The following is a description of a gene set: Cluster 2: genes down-regulated in lung tissue samples from mice with oncogenic form of KRAS and inactivated PTEN. from publication Iwanaga K, Yang Y, Raso MG, Ma L, Hanna AE, Thilaganathan N, Moghaddam S, Evans CM, Li H, Cai WW, Sato M, Minna JD, Wu H, Creighton CJ, Demayo FJ, Wistuba II, Kurie JM (PMID 18281487) Phosphatase and tensin homologue deleted from chromosome 10 (Pten) is expressed aberrantly in non-small cell lung cancer cells, but the role of Pten in lung neoplasia has not been fully elucidated. In this study, we used a genetic approach to inactivate Pten in the bronchial epithelium of mice. Although, by itself, Pten inactivation had no discernible effect on bronchial epithelial histology, it accelerated lung tumorigenesis initiated by oncogenic K-ras, causing more rapid lethality than that induced by oncogenic K-ras alone (8 weeks versus 24 weeks of median duration of survival, respectively). Lung tumors arose in K-ras mutant, Pten-deficient mice that rapidly obstructed bronchial lumina and replaced alveolar spaces. Relative to K-ras mutant tumors, the K-ras mutant, Pten-deficient tumors exhibited more advanced histologic severity and more prominent inflammation and vascularity. Thus, Pten inactivation cooperated with oncogenic K-ras in promoting lung tumorigenesis. Mouse Gene Set: IWANAGA_CARCINOGENESIS_BY_KRAS_PTEN_DN studied in species Mus musculus, and this is the list of marker genes: 4933425D22Rik, Cir1, Ttll8, Hk1, Scfd2, Smg9, 4930532I03Rik, Mmp12, Ndst3, Cacna1a, Gtpbp3, Gnb4, Grm5, Grem1, Ypel3, Cnn1, Sik2, Sox7, Helz, Eef1akmt1 (NCBI Gene Id 68043), Gpd2, Myo5a, Rictor, Angptl2, 4933417C20Rik, Phex, Chrna9, Col4a1, Vps39, Utp14a, Cemip, Zfp58, Arhgap18 (NCBI Gene Id 73910), Cfap91, Pdzd9, Arid4b, Zfhx4, Cd28, Swsap1, Rassf6, Vps51 (VPS51 GARP complex subunit), Gpr107, Hoxb4, Zscan4c, Zswim8, Wasf2, Fgf14, Cript, Adcy8, Osbp, Il2rg, Mast3, Pspc1, Fbxl7, Dpf1, Glis2, Ms4a6b, Sema3e, Fbxw13, Tmtc1, Pde4dip, Hnrnpu, Psen1, Ajm1, Abcb6, Klf7 (NCBI Gene Id 93691), Zfp672, Dpt, Cyp4a31, Map4, Ttc21b, Zbtb14 (NCBI Gene Id 22666), Tcf21, Ptprc, Zbtb44, Tpm1, Cav2, Ints2, Sv2b, Ddn, Pdilt, 9330121J05Rik, Lrp8, Pltp, Gm4924, Ints9, 4933422A05Rik, E230016M11Rik, Klf4, Endog, Cbfa2t3, Ddx50, Ccnjl, 2410004I01Rik, Xpr1 (xenotropic and polytropic retrovirus receptor 1), Xpa, Gpr153, Synm, Vps50, Ndn, Eng, Serping1, Cldn5, 1700092E16Rik, Srd5a2, Zfp839, Gzma, Rhoj, Ogn, Sugp1, Ccdc81, Chic2, Celf6, Pfkfb3, Syn2, Prdm1, Atp10d, Ppp2r5b, Hs3st3b1, Galnt13, Abhd17c, 1700020N01Rik, H1f9, Zzef1, Tmem184b, 5330439K02Rik, Ncald, Glp1r, Daam1, Mblac1, Foxf2, 4930549G23Rik (RIKEN cDNA 4930549G23 gene), Clca4b, Plcg1 (NCBI Gene Id 99130), Ccnd3, Ttc28, Otud3, Tspan13, Tmem263, Hoxb5, Gemin8, Rgs2, Prss59, Coro1a, Cdon (NCBI Gene Id 57810), Cacng2, Susd4, Paxip1 (NCBI Gene Id 55982), Abtb2, Ppbp, Klf6, Adgrl2, Eif4g2, Spart, Rcn1 (reticulocalbin 1), Myt1, 6430710M23Rik (RIKEN cDNA 6430710M23 gene), Chct1, Ndufb10, Slc39a10 (solute carrier family 39 (zinc transporter), member 10), Pappa2, Ccdc134, Rsl24d1, Icos, Proser2, Or5b106, Irs4, B3galnt2, Zmat4 (zinc finger, matrin type 4), Gm9195, Cabp2, Nxn, Fdx2, Zfp52, Mettl17, Brca1, Bgn, Clec14a, Actc1, Clip1, ENSMUSG00000142272, Aldh1a1, Xlr5c, Pmp22, Slc29a2, Fhl1, B3gnt6, Abcd2, Cetn1, 4933403J19Rik, Tmed5, Ms4a6c, Ldb2, Ptprk, Shisa6, Zcchc14, Irf8, Ctif, Sptbn1, Adgre5, Map2, Plod2, Tbc1d24, Pkd2, Kitl, Lockd, Tlx1, Cyth3, Cavin2, Iqgap3, Fzd4, Gimap6, Rgmb, Rasgrp2, Cxcl13, Prpf4b, Ippk, St6galnac3, Oprk1, Slc16a5, H60c, Picalm, Irgq, Scaf4, Pdzd2, Cpne8, Tnpo1, Nek11, Plvap, Erf, Ttc6, Mideas, Cul3, Enpp2, Hebp2, Crisp1, Inmt, Tmem174, Cdt1, Arhgef2, Chsy1, 2810001A02Rik, 2410012E07Rik, Ak4, Ppp1r14a, Gm33727, Man1b1, Smarcd2, Ms4a4d, Amz1, Muc15, Haus3, Calcrl, Clec2l, Smchd1, Hoxa3, Tek, Adrb1, Adh1, Spats2l, Akap12, Fa2h, Dyrk1a, Tmem170, 4921515G04Rik, Ddx27, Gen1, Foxk2, Sntb2, 1700084C06Rik, Cfhr2, Adgrl4, Tra2a, Shfl, Gm9754 (predicted gene 9754), Rpp40, Ttl, Jun, Plxdc2, Arhgef4, Gm7233, Thoc7, Gm11992, Ramp2, Hip1, Tax1bp1, Dclk1, Lig3, Cpeb1os1, 4932435O22Rik, Satb1, Fmo1, Pdlim3, Auh, Marcks, Stpg4, Yod1, Efnb2, ENSMUSG00000126352, Mcam, Txnl1, Serpinb6a, 1810010H24Rik, Tbp, Foxh1, St18, Zfp943, Ankra2, Srek1, Meis2, Map7, Rsf1, Tgm2, 1810021B22Rik, Gsn, Set, Cnr2, Tgfb1i1, Fam229b, Mettl6, Ctdspl2, Vcl, Snai3, Hnrnpf, Slc22a3, Myt1l, Sprr2j-ps, Krt80, Rab10os, Gpr182, Nid1, Mmp2, Ndufv3, Adam1a, 1700010B08Rik, Mtor, Ankrd34a, 4933417E11Rik, Ascl3, Mpdz, Snx21, Sugp2 (NCBI Gene Id 234373), Trnau1ap, Kcng4, Ebf1, Tmem87b, Eid2, Mfsd13b, Hbp1, Oxct1, Mrpl54, Abcb1a, Cycs, Irx1, Insr, B430319H21Rik, Ccdc174, Tnnt2, Ddhd2, Ifit2, Katnbl1, Ssh2, Zeb1, Nsf, Lgalsl2, Elf4, Edc3, 9130221H12Rik, 4933426K07Rik, Btbd6, 4930483J18Rik, Depp1, Itgb3bp, Ears2, Ppp1r14b, Sparcl1, Arhgap25, Cbr3, Gas1, Ston2, H2-Ab1, Pea15a, Paqr5, Gpat4, Amigo1, Grem2, Atp13a4 (ATPase type 13A4), Lrrc72, Cd93, Ptprd, Wwox, Dcp2, Gtf2i, Sell, Klk7, Tcerg1, Itpr2, Gm15201